The following is a description of a gene set: Human Gene Set: HP_EYE_MOVEMENT_INDUCED_PAIN Eye movement-induced pain An unpleasant sensation characterized by physical discomfort (such as pricking, throbbing, or aching) localized to the eye that is worse in certain directions of gaze and during prolonged gaze holding. studied in species Homo sapiens, and this is the list of marker genes: SLC4A11, AGBL1, TCF4, COL8A2, ZEB1